Given this list of marker genes ACACB, PDK4, HS3ST4, GSS (NCBI Gene Id 2937), ELOVL1, ACSL6, GGTLC3, EXTL1, SLC7A11, CTH (cystathionine gamma-lyase), THTPA (NCBI Gene Id 79178), PPT1, ELOVL5, GCLM, ACSBG1, PPCS, UGDH, PANK1, PANK2, ELOVL6, ELOVL3, PDHX, GSTM1, CTNNB1, HS3ST2, PDK1, AKR1A1, HAGH, CSGALNACT1, CYTL1, HS6ST2, TPK1, PDHA2, TCF7L2, CSAD, EXTL2, PANK3, CHAC1, SLC19A2, METTL16, SLC35B2, ACSF3, XYLT2, GGT1, HTD2, GSTP1, ACSS1, MGST2, CHST7, SNCA, MIR21, DIP2A, PDHA1, HS3ST3B1, PPT2, TM9SF2, CHST11, GGT7, HS3ST5, LIAS (lipoic acid synthetase), NDST2, PAPSS2, SLC1A2, IGF1, B3GALT6, MPC2, MAT2B, GGT6, MTR, SLC19A3, FASN, GGTA1, SP1, GSTA1, HS6ST3, NDST3, ACSL1, CBR4, EXT2, SLC35D2, PANK4, GLCE, APIP, HS3ST3A1, DCAKD, GGT3P, ACSL5, GGT2P, SLC27A2, CHSY1, ELOVL7, ACSL3, COASY, MTHFD1, FMO1, MTRR, HS6ST1, DLD, SLC1A1, TECR, HS3ST1, B3GAT3, CHPF, B3GAT1, PXYLP1, GGTLC1, CBS, ELOVL4, GCLC, PGK1 (NCBI Gene Id 5230), PPCDC, ELOVL2, CSGALNACT2 (chondroitin sulfate N-acetylgalactosaminyltransferase 2), SLC25A19 (solute carrier family 25 member 19), FMO3, MPST, ACSL4, B3GAT2, GGT5, EXT1, ADI1, BHMT2, DSE, ACSS2, BCKDK, HACD1, ACLY, PAPSS1, GGTLC2 (gamma-glutamyltransferase light chain 2), HS2ST1, ACAT1, ACSBG2, HSD17B12 (NCBI Gene Id 51144), NFE2L2, ACACA, MLYCD, XYLT1, NDST1, GCDH, CHSY3, CHST13, BHMT, CHST12, CHST3, CHAC2, EXTL3, PDK3, ENSG00000274276, DLAT, MAT1A, CHPF2 (chondroitin polymerizing factor 2), MMUT, HACD2, NDST4, PDK2 (NCBI Gene Id 5164), VANGL2, MAT2A, ACOT7, CDO1, PDHB, HS3ST6, ENOPH1, here is a description of the gene set: studied in species Homo sapiens Human Gene Set: GOBP_SULFUR_COMPOUND_BIOSYNTHETIC_PROCESS The chemical reactions and pathways resulting in the formation of compounds that contain sulfur, such as the amino acids methionine and cysteine or the tripeptide glutathione.